The following is a description of a gene set: A condition in which there is increased production of gastrin by a gastrin-secreting tumor (usually located in the pancreas, duodenum, or abdominal lymph nodes) that stimulates the gastric mucosa to maximal activity, with consequent gastrointestinal mucosal ulceration. Human Gene Set: HP_ZOLLINGER_ELLISON_SYNDROME species: Homo sapiens Zollinger-Ellison syndrome, and this is the list of marker genes: CDKN2B (NCBI Gene Id 1030), MEN1, YY1, PIEZO2, CDKN1A, CDKN2C, GCGR, CDKN1B, ATRX